The following is a description of a gene set: from publication Yevshin I, Sharipov R, Kolmykov S, Kondrakhin Y, Kolpakov F (PMID 30445619) Mouse Gene Set: ZFP599_TARGET_GENES species: Mus musculus, and this is the list of marker genes: Atxn1l, Cox5a, Recql5, Fastkd5, E130006D01Rik, Tmcc3, Mir367, Serpinh1, Pan3, 1700028N14Rik, Atf7ip, Scd1, Sdcbp, Hsp90ab1, Dennd10, Capns1, Tnrc6c, Tatdn2, Mrpl30, Etv1, Polrmt, 1810009A15Rik, Mir195a, Eng, Atad2b, Psmd8, Mlxip, Praf2, Elp6, Gm16096, Spata24, Usp28, Rab3gap2, Tppp3, Sbds, Mbtps2, Nup133, 4930519P11Rik, Nsrp1, Zfp36, Ccdc9, Gm19193, Brwd1, Ppp2r1b, Ube2b, Alad (aminolevulinate, delta-, dehydratase), Foxc1, Plce1, Phykpl, Stat6, Snrpert, Fbxo22, Smim8, Cyp4f13, Hid1, Lsm1, Hsd17b10, Gm16159, Tcea1, Ccdc71l, Zfp280d, Rps19, Dnajb1, Bag4, Dscam, Uba1, 2610037D02Rik, Def8, Ccdc63, Gcnt2, Frmd4b, Fam53b, Ino80d, Ncapd2, Sap30bp, Atp5mc2, Gm10138, Fbxl17, Virma, Pyroxd2, Tmem109, Slc4a1 (solute carrier family 4 (anion exchanger), member 1), Dubr, Junos, Nsd1, Mir7646, Mylpf, Stat3, Ino80dos, Mir302c, Cfap298, Nherf1, Eddm13, Elf2, Trim6, Angpt2, Limk1, Ier3, Fah (NCBI Gene Id 14085), Ubox5, Sugp2, Ubxn2b (NCBI Gene Id 76194), Rfwd3, Auh, Mir423, Ubr3, Prdm1, Hsf4, Clcn6, Luc7l, Polr1c, Vps4a, Nxpe3 (NCBI Gene Id 385658), Rnu11, Cops3, Dync1li1, Jun (NCBI Gene Id 16476), Kcna1, Mtcl3, Or2au1-ps1, Gstp3, Ttc17, Mrps9, Rora (NCBI Gene Id 319897), Tmppe, Atp8b3, Foxn2, Gm21917 (NCBI Gene Id 102638921), E130102H24Rik, Hint3, 1700030C12Rik, Specc1l, Strip1, Lgr4, Ttc9c, Mtfr1, Eif4e3, Yipf3, A930018P22Rik, Mrps30, Tceanc2, Hoxc6, Parp11, Oas1c (2'-5' oligoadenylate synthetase 1C), Taf9b, Prpf38b, Zmiz1, Mir615, Rassf10, Hspb1, Pdrg1, 5530601H04Rik, Mgat4f, Nufip2, Oxt, Zdhhc5, Tmem59, Zfp36l1 (zinc finger protein 36, C3H type-like 1), Tom1l2, Nrbp1, Uba5, Psenen, Psma3, Snora26, Gm10010, Cers2, Snhg8, Ctsd, Arhgap18, Chrna9, Pigv (phosphatidylinositol glycan anchor biosynthesis, class V), Larp4, Tiprl, Gatad2b, Gm11962, Msantd2, Cdkn2aipnl, Tkt, Gng2, Ube2d3, Ogdh, Mir497, Wtip, Higd1a, Nubp1, Twf1, Ctnnb1, Dancr, 4930539J05Rik, Mrpl51, Odad1, Sirt1 (sirtuin 1), Snora24, Mbtps1, Dnase2a, Stpg2, Ndufs2, Vdac2, Birc2, Lin28b, H3f3a, Gm13777, Cyp2b23, Pttg1ip, Myo18a, Mir688, Glb1 (galactosidase, beta 1), Atp6v0c, Pate2, Ahsa2, Mcf2, Nsl1, Adamts4, Hdgfl2, U2af1l4, Acad11, Tmem9, Eid1, Acss1, Gm6140, Ndufaf6, Zfp207, Gm42921 (NCBI Gene Id 118568586), Hnrnpul2, Mier2, Ly6l, Oas1b, Zfp346, Hdac7, Slc12a4, 4930502E09Rik, Nqo1, Fbxo27, Sp1, Coa7, Slc9a8 (NCBI Gene Id 98868), Trappc3, Mir302d, Map3k14, Usp6nl, Rhof, Plekha7 (NCBI Gene Id 233765), Mir302a, Runx1 (NCBI Gene Id 12394), Scly (selenocysteine lyase), Mthfr, Lnpep, Gm29155, Atg13, Trir, Mir302b, Zmpste24, Klf8, Mitd1, Gdpd1, Ints5, Lamr1-ps1